Given this list of marker genes MGST1, EXTL1, SEMA3B, KRTAP19-1, ARRDC2, CERS4, CALHM5, PRKCB, E4F1, SLURP2, PLEKHH2, SS18L2, PNPLA5, H2BC5, WDR47 (WD repeat domain 47), PDLIM4 (NCBI Gene Id 8572), PECR, GUK1, AAMDC, TMEM218, TRUB1, STMN1, MMRN1 (multimerin 1), HGH1 (HGH1 homolog), AMIGO1, NUDT21, GAS2, TNFRSF18, HSD17B10, SLC15A2, PAOX, PTH1R, PTTG1, SIRPA, RGMA, RPAIN, RPP38, SLC45A3, P3H3, H2BC3, S100A3, RFC3, ELOVL3, ELOVL6, KIF2A, NDUFS7, CKB, CA2, DAPL1, OLAH, HSPB8, H2BC13, PTS, LGALS4, COL16A1, ACAT1, ADH1A, HSD3B2, MDH1, STOML1, SMPDL3B, MLH1, BPHL, SLURP1, CASZ1, KRTAP5-2, PANK4, CALML5, CENPL, OAS1, NFIL3, SCD, DBP, KRT2, TNMD, H1-4 (H1.4 linker histone, cluster member), BOLA1, MAOA, KRT36, AWAT1, NSD2, ACOXL, MT1X, H2BC4, CYP17A1, RPP40, C1QTNF12 (NCBI Gene Id 388581), TENT5A, IGFBP5, DOC2GP, LTBP3, NOP10 (NOP10 ribonucleoprotein), C7orf25, here is a description of the gene set: Human Gene Set: DURCHDEWALD_SKIN_CARCINOGENESIS_UP Expression and function of the oncogenic transcription factor activator protein (AP-1; mainly composed of Jun and Fos proteins) is required for neoplastic transformation of keratinocytes in vitro and tumor promotion as well as malignant progression in vivo. Here, we describe the identification of 372 differentially expressed genes comparing skin tumor samples of K5-SOS-F transgenic mice (Fos(f/f) SOS(+)) with samples derived from animals with a specific deletion of c-Fos in keratinocytes (Fos(Deltaep) SOS(+)). Fos-dependent transcription of selected genes was confirmed by quantitative real-time PCR analysis using tumor samples and mouse back skin treated with the tumor promoter 12-O-tetradecanoylphorbol-13-acetate (TPA). One of the most differentially expressed genes encodes the small mucin-like glycoprotein Podoplanin (Pdpn), whose expression correlates with malignant progression in mouse tumor model systems and human cancer. We found Pdpn and Fos expression in chemically induced mouse skin tumors, and detailed analysis of the Pdpn gene promoter revealed impaired activity in Fos-deficient mouse embryonic fibroblasts, which could be restored by ectopic Fos expression. Direct Fos protein binding to the Pdpn promoter was shown by chromatin immunoprecipitation and a TPA-induced complex at a TPA-responsive element-like motif in the proximal promoter was identified by electrophoretic mobility shift assays. In summary, we could define a Fos-dependent genetic program in a well-established model of skin tumors. Systematic analysis of these novel target genes will guide us in elucidating the molecular mechanisms of AP-1-regulated pathways that are critically implicated in neoplastic transformation and/or malignant progression. Genes up-regulated upon skin specific knockout of FOS by cre-lox in the K5-SOS-F mice (express a constitutively active form of SOS1 in the skin). studied in species Mus musculus from publication Durchdewald M, Guinea-Viniegra J, Haag D, Riehl A, Lichter P, Hahn M, Wagner EF, Angel P, Hess J (PMID 18757399)